Given this list of marker genes FADS1, ELOVL3, FADS2, ACSL1, ABCD1, ELOVL2, ELOVL1, ELOVL5, here is a description of the gene set: part of: alpha-linolenic (omega3) and linoleic (omega6) acid metabolism Reactome Pathway: Linoleic acid (LA) metabolism species: Homo sapiens Linoleic acid (LA, 18:2(n-6)) is an omega-6 fatty acid obtained through diet, mainly from vegetable oils. Omega-6 fatty acids helps stimulate skin and hair growth, maintain bone health, regulate metabolism, and maintain the reproductive system. All the desaturation and elongation steps occur in the endoplasmic reticulum (ER) except for the final step which requires translocation to peroxisomes for partial beta-oxidation. The linoleic acid pathway involves the following steps: 18:2(n-6)-->18:3(n-6)--> 20:3(n-6)-->20:4(n-6)-->22:4(n-6)-->24:4(n-6)-->24:5(n-6)-->22:5(n-6). Two desaturation enzymes are involved in this process: delta-6 desaturase which converts 18:2(n-6) to 18:3 (n-6) and 24:4(n-6) to 24:5(n-6) respectively, and delta-5 desaturase which converts 20:3(n-6) to 20:4(n-6)..